The following is a description of a gene set: Human Gene Set: GOCC_AXON_HILLOCK Portion of the neuronal cell soma from which the axon originates. species: Homo sapiens, and this is the list of marker genes: SERPINF1, PRKCZ, AURKA, TPX2, SPTBN4, NDEL1 (nudE neurodevelopment protein 1 like 1), MAP2